Given this list of marker genes Med19, Hapstr1, Cetn2, Elfn2, Fgd3, Snx12, Nadk2, Lsm12, Slc16a3, Zfp710, Rtf1, 0610010K14Rik, Zfp609, Twf1, Prdm15, Lonrf2, Gcc2 (GRIP and coiled-coil domain containing 2), Iqcg, Pcbp4, Prtg, Stim2, Naa15, Atp2b4, Pgf, Baz2a, Cbx2, Limd1 (NCBI Gene Id 52216), Galnt7, Myrip, Kif7, Hmg20a, Rexo2, Sema4d, Cmtm4 (CKLF-like MARVEL transmembrane domain containing 4), Hoxa4, Hspb1, Tmem268, Gas7, Purb, Sec24c, Rcsd1, Tab3, Cnr2, C9orf72, Vps28, Ammecr1l, Ptprj, Tmem161b, Aph1c, Tspan11, Lrrc1, Zbtb41, Irf2bp2, Gpn1, Myo18a, Pml, Ppip5k1, Plagl2, Sall4, Atp8a1, Ccdc96, Fgd5, Luzp1, Gdnf, Smarcd1, Dolpp1, Mapre1, Ezh1, Fgfr1, Glyctk, Tmem33, Ccdc167, Wnt3, Clint1, Peli3, Vgll1, Sbk1, Tmem248 (transmembrane protein 248), Cdipt, Mrps2, Myoz3, Sigmar1, Fgf14, Slc8a1, Nalf1, Rapgefl1, Rab4b, Clasp1, Akap13, 1700010I14Rik, Cd247, Kpna1, Eola1, Neo1, Tchp, Cadm1, Prr14l, Tmem209, Cbl, Il17rd, Tgoln1, Slc16a1, Oxr1, Eif3b, Usp20, Rc3h1, Lhx6, Naa50, Tbc1d5, C5ar1, Abtb3, Mecom, Trim66, Phf6 (NCBI Gene Id 72524), Wnt2 (wingless-type MMTV integration site family, member 2), Nmb (neuromedin B), Dcun1d1, Tmem130, Vwde, Gpr63, Dll1, Cntnap1, Itgb8, Gpd1, Zbtb8b, Ipo11, Naa30, Tanc2, Sox8, Crtac1, Wdtc1, Pcdh20, Adap1, Enox2, Fign, Arl2, Mcoln2, Hbegf, Zfand3, Ndc1, Zbtb39, Ncs1, Rubcn, Diablo, Mllt10, Pycr1, Ptdss1 (phosphatidylserine synthase 1), Fcho1, Tspan9, Zbtb10, Ppp6c, Kif21b, Leprotl1, Nufip2, Ppme1, Scp2d1, Cpsf4 (cleavage and polyadenylation specific factor 4), Rab14, Exoc3, Bcl11a, Rasgef1c, Ackr2, Rexo1, Zbtb40, Hykk, Rnd1, Pim1, Stx8, Abcc5, D430041D05Rik, Plpp1, Hnrnpu, Hr, Psmg2, Mlxip, Pter, Nfatc2, Pdrg1, Jakmip2, Arvcf, Fchsd1, Kbtbd2, Qki, Pym1, Eps8l1, Mapk8 (NCBI Gene Id 26419), Gusb (NCBI Gene Id 14929), Pcbp2, Afmid, Fndc5, 6430548M08Rik, Hdgf, Mtcl2, Tbl1xr1, Nol10, Ldoc1, Creb1, Ddx17, Nol7, Mrtfb, Pdcl2, Fbln5, Mrc2, Ralgapb, Bcl2l11, Snx29 (sorting nexin 29), here is a description of the gene set: Genes predicted to be targets of miRBase v22 microRNA mmu_miR_214_3p in miRDB v6.0 with MirTarget v4 prediction scores > 80 (high confidence targets). Mouse Gene Set: MIR_214_3P species: Mus musculus from publication Chen Y, Wang X (PMID 31504780)